The following is a description of a gene set: species: Mus musculus Mouse Gene Set: GOBP_MIRNA_CATABOLIC_PROCESS The chemical reactions and pathways resulting in the breakdown of miRNA, microRNA, a class of single-stranded RNA molecules of about 21-23 nucleotides in length, which regulates gene expression., and this is the list of marker genes: Zswim8, Snd1, Tent4b, Elob, Dis3l2, Parn, Eloc, Pnpt1, Lin28b, Tut4, Zc3h12a, Qki, Lin28a, Tent2